The following is a description of a gene set: studied in species Homo sapiens The binding by a cell-adhesion protein on the cell surface to an extracellular matrix component, to mediate adhesion of the cell to the extracellular matrix. Human Gene Set: GOMF_CELL_MATRIX_ADHESION_MEDIATOR_ACTIVITY, and this is the list of marker genes: ITGA9, ITGA11, SVEP1, ITGA2, MADCAM1, ITGA10, ITGA1, ITGB1, EMILIN1